The following is a description of a gene set: Human Gene Set: FAN_EMBRYONIC_CTX_MICROGLIA_2 species: Homo sapiens from publication Fan X, Dong J, Zhong S, Wei Y, Wu Q, Yan L, Yong J, Sun L, Wang X, Zhao Y, Wang W, Yan J, Wang X, Qiao J, Tang F (PMID 29867213), and this is the list of marker genes: IER3, IER2, FOSB, MIR23AHG, IL1B, PPP1R15A, CCL4, CCL3, CD83